Given this list of marker genes SH3BP2, TNFRSF11B, CFI, NMNAT1, HLA-A, here is a description of the gene set: studied in species Homo sapiens Scar tissue in the macula. Human Gene Set: HP_MACULAR_SCAR Macular scar